Given this list of marker genes ELK1, MAPK1, BCL2, TBP, RFX5, HSPA5, HSP90B1, SMC3, PTK2, POU2F2, CTCF, MAPK3, NFKB1, PRNP, FYN, MEF2C, IRF4, CASP3, FGFR1, STAT3, RXRA, NCAM1, SPI1, BCL11A, EBF1, PAX5, BATF, CHD2, EP300, PDIA3, RAD21, CREB1, here is a description of the gene set: species: Homo sapiens Prion disease pathway Human Gene Set: WP_PRION_DISEASE_PATHWAY